Given this list of marker genes Slc25a18, Slc1a2, Slc1a7, Ucp2, Slc17a8, Slc1a4, Slc7a11, Slc13a3, Slc1a6, Slc25a22, Slc1a1, Slc38a6, Slc25a13, Slc17a6, Slc17a7, Slc25a12, Slc1a3, Grik1, Slc38a2 (solute carrier family 38, member 2), Slc1a5, here is a description of the gene set: Enables the transfer of acidic amino acids from one side of a membrane to the other. Acidic amino acids have side chains with a negative charge at pH 7.3. studied in species Mus musculus Mouse Gene Set: GOMF_ACIDIC_AMINO_ACID_TRANSMEMBRANE_TRANSPORTER_ACTIVITY